The following is a description of a gene set: Cerebellar dysplasia species: Homo sapiens Human Gene Set: HP_CEREBELLAR_DYSPLASIA Cerebellar dysplasia (abnormal growth or development) is defined by abnormal cerebellar foliation, white matter arborization, and gray-white matter junction. Cerebellar dysplasia is a neuroimaging finding that describes abnormalities of both the cerebellar cortex and white matter and is associated with variable neurodevelopmental outcome. Dysplasia may globally involve the cerebellum or affect only one cerebellar hemisphere. In addition, cerebellar dysplasia may be associated with cortical/subcortical cysts., and this is the list of marker genes: PTEN, POMGNT1, ARMC9, IDH1, MICU1, ADGRG1, FKTN, COG1, PI4KA, LARGE1, KIAA0586, B3GALNT2, BLTP1, POMT1, GPSM2, SRPX2, THOC2, FKRP, RAC1, POMT2, LAMA1, RXYLT1, CDC42 (NCBI Gene Id 998)